The following is a description of a gene set: studied in species Homo sapiens Genes containing one or more binding sites for (ZNF584) in their promoter regions (TSS -1000,+100 bp) as identified by GTRD version 20.06 ChIP-seq harmonization. from publication Yevshin I, Sharipov R, Kolmykov S, Kondrakhin Y, Kolpakov F (PMID 30445619) Human Gene Set: ZNF584_TARGET_GENES, and this is the list of marker genes: NPRL2, UBA5, B3GAT3P1, CCDC88A, PTP4A2, IRF2BP2, IL23A, P4HB, XIST, SCMH1 (Scm polycomb group protein homolog 1), SULT2B1, CDK5RAP2, USF2, TMEM140, RAD9B, SLC7A5, PRR5, RNF32, TMEM115 (NCBI Gene Id 11070), MIR7-3HG, CHCHD2P1, PRKCA, SMPD3, SLC9A6, MIR5093, ARMH4, CASK, ASAP3, SLC25A6, RN7SKP249, MTMR4, USP20, UBAC1, LSM10, RALGDS, TRAJ10, ENSG00000253986, MIR130AHG, LRBA, GTF2IRD1, DNAJB5, MAPK13, PTBP1 (polypyrimidine tract binding protein 1), HMBOX1 (homeobox containing 1), PPP2R3B, MIR7-3, AKT3, NUPR1, HEMGN, PLEKHF2, CABIN1, SLC39A3, MAPK8IP2, DNHD1, RAB7A, ZSCAN31, RFFL, RPL23AP77, ZMAT1, BARHL1, MYO3B-AS1, KPNB1, MYO5B, USP31, NEUROD4, IQSEC3P3, ADGRB3-DT, SEC24C, CD22, TAL1, UBE2E2-DT, SUCLA2, PPP6R1, ARID4A, PI16, ITGAM, UBE2E3-DT, MPND, LINC02842, ZNF175, RPL23AP63, ABRAXAS2, CALM3, FLYWCH1, TANC1, MARCHF2, AGER, GNL3L, UNC13A, SPINK4 (serine peptidase inhibitor Kazal type 4), NUDCD3, PRKAB1 (protein kinase AMP-activated non-catalytic subunit beta 1), DHRSX, C6orf89, PGP, ALG6, DYNC1I2, ATP6V0A1, NUDT13 (nudix hydrolase 13), LINC02985, ACTG1, MIR4441, PCSK6, NPEPPSP1, LNCATV, CYB5R4, CALCOCO1, TRIB3, PNPLA1, TBC1D25, SNX12, RNU4-71P, ADGRB3, FEM1A, CTTN (cortactin), CCRL2, LYL1, PSMA3-AS1, AP3B2, COX6CP5, SORD2P, VPS29 (NCBI Gene Id 51699), ZC3H4, LINC02928, CDCA3, TMEM233, RN7SKP192, FAXDC2, SRD5A3-AS1, IKBKB-DT, INTS4, AKR1E2, PCBP1-AS1, AKT1S1, UBE2Q2, SCYL3, ENSG00000249713 (novel transcript), IFRD2, ENSG00000227706, GYPE, UBE2E2, RN7SKP168, SEPHS2, GFER, CHD4, CYREN (NCBI Gene Id 78996), NFASC, HPN, ENSG00000260288, LINC01732, LEPROTL1, MYCL, METTL13, DNAJB2, TMEM268, RNY3P11, OR8G1, CCR5AS, NAGLU, TRPC7 (NCBI Gene Id 57113), TCEA2 (NCBI Gene Id 6919), TSNAXIP1, POPDC2 (NCBI Gene Id 64091), KDM2A, SLC22A18, HNRNPH1, ENSG00000266401, SCRT1, CCDC174, LLGL2, ARPC2, NOXO1, SVOP (SV2 related protein), KCTD20, TKT, METTL3, FARSA, GLRA1, ST7-OT4, PDLIM7, UNK, ST7, AK2, GGT1, KPNA4, GNG4, LCOR, SNAP25-AS1, MKKS, HDAC6, ENSG00000235978, TRMT12, MAP1LC3B2, SOX6, KCNAB1, WSB1, CLCN3, CIMAP1B, STAP2, BABAM1, AHI1, MUS81, USP9X, PPFIA4, SCG2, OPLAH, FAM53C, OTUD7A, HM13, TBC1D17, ALDH1A2, UTP11, ANKRD65, LINC03016, ENSG00000206898, SPTAN1, LINC01521, LINC01890, TBX6, ATF7IP2, NFE2 (NCBI Gene Id 4778), ART4, KCNH6, NOSIP, FCHSD2, DAXX, SCAMP5, ALG1L13P, MIR4766, IQGAP2, TMA7B, LHFPL4, MAPK11, IFI16, TMEM14B, RPH3AL, GALE, SLK, ST3GAL2, TMEM260, ADGRV1, CCDC137P1, CDK5, UBE2O, CDH23, SCG3 (NCBI Gene Id 29106), MSR1, TCERG1, TPM4, SETD5, RPL29P20, XPO6, SYP, TMEM11-DT, ZFYVE1, CARD8-AS1, STRIP1, SLC4A2, MEF2C, CLP1, WIPF1, SLC7A5P1, TMEM11, RIN3, WWC2-AS1, NFIX, TILAM, SCAT2, SRSF4, DOLPP1, EOGT, LEMD2, SSBP4, CPNE2, ERI1, CXXC1, UBE2E3, C3orf86P, KLKP1, UCKL1, CLPX, F2RL3, ZBTB8OS, KBTBD7, PPP4R1L, C12orf76, TXNDC15, ZNF649, CFL1, MEGF11, CADM3-AS1, SMARCA4, CLPB, YPEL4, KHSRP, UBE3C, GPR158, CLSTN1, VDAC2, RMND5A, AP2A2, HSPA9, SFI1 (SFI1 centrin binding protein), MYH9, MAN2A2, PLAU, CRADD, ADD1, RANBP10, CEP95, TXNDC11, FBXL19, THRB-AS1, PKD1L2, PAFAH2, RBBP4, GTPBP2, PXT1, LTBP1, TMEM161B, DRC1, ARHGAP25, H3-3B (NCBI Gene Id 3021), HTR5A, BOD1, KCNK1, CARMIL2, NSD1, TRAC, PATZ1, NECTIN4-AS1, KRTAP2-4, B3GNT5, IL1R1, BMAL1, INTS9, CNOT1, SUMO3, CBFA2T3, HMX3, GSPT1, KCNB1, FASN, WDR4, CDYL, TRIM29, C1orf159, SLX4IP, ILK, TULP2, SNX19, KPNB1-DT, NPPB, TMEM181, MASP1, SAMD9L, CYB561D2, AP2S1, BFSP2-AS1, ANTXR2, PPP1R15A, NUMA1, CHMP3, ENSG00000253887, PHF21A, EHBP1L1, NDUFA4, IMPACT, RNA5SP60 (RNA, 5S ribosomal pseudogene 60), DIXDC1, OGDHL, PANK4, PPP5D1P, LINC02252, MPV17L2, RN7SL717P, ANKS6, SLC48A1, MUC20-OT1, TTC33, MEF2C-AS1